Given this list of marker genes ALDH6A1, GCA, C4orf51, BMAL2, SERPINB9, PTN (NCBI Gene Id 5764), AGXT2, PKN2, CENPK, WDR7, RCHY1, DCLRE1B, RPS3, SPRTN, LRRCC1, SNX30, KMT5B, MTRF1L, SLC38A2, TRAF3IP3, ZNF813 (NCBI Gene Id 126017), LRP6, PSMB11, TNPO1, PLAA, ZNF845, DLGAP4, RBM47, SRSF12, MRPL48, EYA1, BTBD8, ATP2C1, SOX8 (SRY-box transcription factor 8), ANKS1A, PIP4P2, DTD1, METTL4, TRIM49, DGKH, RNF139, CREB5, CLDN12, OTUD4, TRIM49C (tripartite motif containing 49C), OGFOD1, CDK14, PMP2, SPCS3, SRSF2, CAPS2, WDR93, ZNF830, WDHD1, ORC4, ZNF699, HOMEZ, QSER1, MED20, NANOG, KLHL13, ZNF701, ARMC8, FAT3, MACC1, ZNF451, GFM2, RPGR, MARK1, here is a description of the gene set: species: Homo sapiens Human Gene Set: MIR4777_3P from publication Chen Y, Wang X (PMID 31504780) Genes predicted to be targets of miRBase v22 microRNA hsa-miR-4777-3p in miRDB v6.0 with MirTarget v4 prediction scores > 80 (high confidence targets).